Given this list of marker genes Sgo2a, Ythdf3, Rab6b, Tube1, Yy1, Thap1, Jag2, Ppp1r14c, Irx3, Clcf1, Jph1, Taf4b, Kif20b, Hdx, Nmral1, Ncoa2, Hbp1, Nlgn1, Dennd4a, Ubr1, Prr12, St8sia3, Cpsf6, Ppfia1, Golga2, Gpr158, Rnf144a, Cnpy1, Tln2, Ptbp3, Ranbp3l, Abca8a, Pip5k1b, B3gnt5, Taok1 (TAO kinase 1), Gria3, Lgr4, Pum2, Tut4, Dll4, Dmtf1, Emp2, Foxo1, Rpl22, Syvn1, Trpm7, Lpar4, Ankrd17, Tusc3, Trpc7, Cibar1, Frmd6 (FERM domain containing 6), Nktr, Tbc1d15, Lrif1, Arid4b, Wapl, Cwc22, Hoxa9, Myh10, Mdm1, Rnf2, Ano4 (anoctamin 4), Ppp4r3b, Gdap2, Fbxo45, Lin9, Dcaf10, Nr0b1, Bche, Trim63, Ppp4r2, Septin9, Selenok, Adgrg2, Col11a1, Itm2b, Skil, Pnn, Cdk1, Frs2, Dek, Kif11, Apaf1, Nbea, Srsf1, Klf4, Dnajc27, Slain2, Arih1, Insm2, Dcc, Ipo8, Ppp1r15b, Cadm1, Ccdc117, Kif1b, Adamts3, Spred1, Btf3l4, Vezf1, Grhl3, Med14 (mediator complex subunit 14), Zfyve21, Ube2e2, Met, Pdap1, Zbtb22, Fam117a, Pi4ka, Hmgxb4, Thrb, Wac, Nedd9, Ccng2, G2e3, 9330159F19Rik, Zc3h11a, Cbx5, Rabggtb, Zbtb41, Psd3, Cilk1, Mast4, Pcdh8, Gramd4, Esr2, Zfp532, Kbtbd6, Ralgapa2, Mblac2, Ank3, Hook3, Dcun1d4, Gtf2i, Zmym6, Pds5b, Atp6v1h, Sorbs1, Tiprl, Zfp715, Fbxo33, Zfyve16, Hivep1 (human immunodeficiency virus type I enhancer binding protein 1), Agap1, Gpc6, Slc38a2, Pdpn, Epb41l1, Rtn1, Spock3, Chd2, Syncrip, Fgfr2, Fut9, Cnot2, Kpna3, Zswim4, Kras, Inpp5f, Kalrn, Sh3gl3, Ubap2l, Suclg2, Mitf, Zbtb18, Nptn, Jph3, Stx12, Nfkbia, Siglecf, Scaf8 (NCBI Gene Id 77962), Jade2, Tm9sf2, Xpo7, Cnot7, Pnrc1, Zfpm2, Foxd4, Lef1, Gad1, Rap2c, Zfp800, Acvr2b (activin receptor IIB), Syt14, Bltp1, Med13, Sp4, Anks1b, Rsrp1, Nr3c1, Wnt5a, Ubn1, Cacna1c, Vcpip1, Pcgf5, Rab10 (NCBI Gene Id 19325), Id1, Arpp21, Npy, Lrp6 (low density lipoprotein receptor-related protein 6), Gucy2f, Phf2, Stk17b, Camta1, Tmem39a, Slmap, Srsf5, Nr5a2, Trappc2, Nexmif, Gtf2a1, Oxr1, Prpf38b, Fbxo43, Crk, Rnpc3, Fam107b, Cnot6l, Fbxo34, Rab2a, Casp8ap2, Reln, Sgtb, Med23, Actr3, Chst2, Mphosph9, Lrrc4, Syngr3, Erf, Plekhg5, Etl4, Khdrbs2 (KH domain containing, RNA binding, signal transduction associated 2), Paxbp1, Atad5, Cbln4, Osbpl3, Adrb2, Sox9, Myct1, Ptp4a1, Ythdf1, Eif4g3, P2ry10b, F3, Npy1r (neuropeptide Y receptor Y1), Meox2, Kdsr, Lrrc1, Lzts2, Grm8, Kctd12, Son, Nol9, Ocln, here is a description of the gene set: from publication Chen Y, Wang X (PMID 31504780) Genes predicted to be targets of miRBase v22 microRNA mmu_miR_539_3p in miRDB v6.0 with MirTarget v4 prediction scores > 80 (high confidence targets). species: Mus musculus Mouse Gene Set: MIR_539_3P